Given this list of marker genes TNFAIP3, GCK, MIDN, FAM118B, AP1S2, DOCK3, ERGIC1, ZEB1, PFAS (NCBI Gene Id 5198), KAZN, LRP4, SIPA1L1, TMEM214 (transmembrane protein 214), ISY1, SSH2, C9orf40, UNK, ITK, LRRC8D, DNAJB2, IL13RA2, IRAK1BP1, RHBG, PLAGL1, SPN, PRDX6, FTH1, RPA3, SERP1, REXO4, SNX9, GIMAP1, ADH1C, GDI2, RGS1, TNFRSF21, CTLA4, ENAM, RNF138 (ring finger protein 138), AGPAT4, HSPA8, ARL6IP6, SNX18, ALDH3A2, GABRQ, PIGB, CNBP (CCHC-type zinc finger nucleic acid binding protein), SH3BP5, TSG101, ATP6V1C2, CBFB, STK33, SEC61A1, NCOA6, LRATD1, VAMP4, ACTG1, IL10, TM6SF1, JUNB, ATP1B4, FOS, INTS5, MECOM, KLF7, SPRED2 (NCBI Gene Id 200734), SLC5A3, FUCA1, SELENOS, C5orf63, SLC16A6, AP3B1 (NCBI Gene Id 8546), LONRF1, OXNAD1, SPATA6, ZNF708, SORCS3, PRPF8, ZDHHC24, MELK, MYL6, TRAPPC2, CNFN, ZNF23, CHD2, SEC23IP, CALHM2 (NCBI Gene Id 51063), RLBP1, PSPH, FANCB, RAB3IP, DUSP5, SH3RF1, MIDEAS, NEIL1, WASHC4, GABRB3, H2AB2, KLHL2, BMP1, DNAJC12, COQ8A, CCDC97, SLC1A3, EIF4EBP2, VPS37B, LAG3, ITGAV (integrin subunit alpha V), CREB3L2, CSRNP2, SH3D19, TRNT1, FOSL2, TENT5A, ID2, EPS8L1, CCDC51, MTCH1, MSRB3, STX11, ZNF616, DGAT2, GPBP1, NR4A2, NEFM, TFE3, RELL1, AEBP2, HIF1A, CPM, EMC10, TCEAL9, SDF4, KCTD12, TRAM1, HIRA, RUNX2, EPRS1, PRKCB, GRAMD2B, MYL12B, TBC1D30, PHLPP1 (PH domain and leucine rich repeat protein phosphatase 1), NFIL3, EYA3, RPAP3, KIF20B, PLEKHG3, CHST11, LDAF1, TRAF1, NRDC, NFKBIE, ADORA2A, PPP1R14A, MDN1, LDHAL6B, TXNDC5, CUL2, CEL, WRAP73, RRAD, ERLIN2 (NCBI Gene Id 140906), HOXA13, ARNT, CHAC2, AKAP12, CNDP2 (NCBI Gene Id 55748), NR2F6, MIA3 (MIA SH3 domain ER export factor 3), GADD45A, GAS2L3, SIX1, PIP4K2A, MXI1, RALGAPB, TTC28, SEMA4B, PLXNC1, DNAAF2, NAGA, HSPA2, DCP1B (NCBI Gene Id 196513), SS18, LIN54, BET1L, PRKAB1, DGCR2 (DiGeorge syndrome critical region gene 2), GADD45B, EMD, TNFRSF18, GCNT1, IFRD1, WNT9A, CBY1 (chibby 1, beta catenin antagonist), RASA2, SCYL1, H2AZ1 (NCBI Gene Id 3015), IL6ST, NSMF, here is a description of the gene set: species: Homo sapiens Human Gene Set: GSE30971_CTRL_VS_LPS_STIM_MACROPHAGE_WBP7_HET_4H_UP from publication Austenaa L, Barozzi I, Chronowska A, Termanini A, Ostuni R, Prosperini E, Stewart AF, Testa G, Natoli G (PMID 22483804) Histone methyltransferases catalyze site-specific deposition of methyl groups, enabling recruitment of transcriptional regulators. In mammals, trimethylation of lysine 4 in histone H3, a modification localized at the transcription start sites of active genes, is catalyzed by six enzymes (SET1a and SET1b, MLL1–MLL4) whose specific functions are largely unknown. By using a genomic approach, we found that in macrophages, MLL4 (also known as Wbp7) was required for the expression of Pigp, an essential component of the GPI-GlcNAc transferase, the enzyme catalyzing the first step of glycosylphosphatidylinositol (GPI) anchor synthesis. Impaired Pigp expression in Wbp7-/- macrophages abolished GPI anchor-dependent loading of proteins on the cell membrane. Consistently, loss of GPI-anchored CD14, the coreceptor for lipopolysaccharide (LPS) and other bacterial molecules, markedly attenuated LPS-triggered intracellular signals and gene expression changes. These data link a histone-modifying enzyme to a biosynthetic pathway and indicate a specialized biological role for Wbp7 in macrophage function and antimicrobial response. Genes up-regulated in bone marrow-derived macrophages with heterozygous MLL4 knockout: control versus treated with LPS for 4h.